Given this list of marker genes Psma1, Psma4, Ap2s1, Ap2m1, Rps27a, Ubb, Fzd4, Smurf1, Psmd1, Arrb2, Ap2a1, Psma6, Psmd13, Fzd2, Psmc4, Wnt4, Psmb5, Psma3 (NCBI Gene Id 19167), Psmc5, Psmc2, Prkcg, Psmd7, Psma5, Prkca, Wnt5b, Cltb, Psma2, Psmc3 (proteasome (prosome, macropain) 26S subunit, ATPase 3), Fzd6, Psmb7, Psmb6, Pfn1, Wnt1, Psmc6 (NCBI Gene Id 67089), Rac2, Dvl2, Psmb4, Fzd8, Dvl3, Psmd12 (proteasome (prosome, macropain) 26S subunit, non-ATPase, 12), Dvl1, Ap2b1, Fzd7 (frizzled class receptor 7), Psmc1, Rac3, Psmd6, Wnt11, Fzd1, Psma7 (proteasome subunit alpha 7), Smurf2, here is a description of the gene set: electronically inferred by orthology from the curated human pathway This event has been computationally inferred from an event that has been demonstrated in another species.<p>The inference is based on the homology mapping from PANTHER. Briefly, reactions for which all involved PhysicalEntities (in input, output and catalyst) have a mapped orthologue/paralogue (for complexes at least 75% of components must have a mapping) are inferred to the other species. species: Mus musculus part of: Beta-catenin independent WNT signaling Reactome Pathway: PCP/CE pathway